The following is a description of a gene set: Butterfly vertebrae A butterfly vertebra (sagittal cleft vertebra or anterior rachischisis) is a sagittal defect in the vertebral body caused by failure of fusion of the two lateral chondrification centers during embryogenesis. The name is based on the appearance of the two hemivertebrae emerging as butterfly wings from the central cleft on x-ray. studied in species Homo sapiens Human Gene Set: HP_BUTTERFLY_VERTEBRAE, and this is the list of marker genes: HAAO, IPO8, NKX3-2, MBTPS2, OTUD5, KDM6A, ARSL, LAMA5, SIX6, TBX6, KMT2D, FOXF1, SOX2, SOX5, WBP11 (NCBI Gene Id 51729), COG1, RIPPLY2 (ripply transcriptional repressor 2), STAG2, SC5D, ALG12, CSGALNACT1